Given this list of marker genes Msi1, Lat, Liat1, Mavs, Alkbh5, Rxrg, Fam81a, Caprin1, Trp53, Cgas, Wnk1, Mecp2, Nup153, Nup98, Ezh1, Nck1, Ddx4, Prnp, Ccnt1, Nfe2l2, Ubqln2, Fus, Syt1, Lgals3, Blnk, Ar, Nlrp3, Surf6, Tardbp, Fxr1, Daxx (Fas death domain-associated protein), G3bp2, Hnrnpa2b1, Nlrp6, Fmr1, G3bp1, Mki67, Nlrp1a, Myoz1, Sqstm1, Sos1, Spata18, Wnk3, Brd3, Zar1, Nlrp1b, Cidec, here is a description of the gene set: Binding and bringing together two or more macromolecules in contact, permitting those molecules to organize as a molecular condensate. Mouse Gene Set: GOMF_MOLECULAR_CONDENSATE_SCAFFOLD_ACTIVITY studied in species Mus musculus